Given this list of marker genes Nt5c3, Ada, Dpyd, Cda, Dpys, Pnp, Upp1, Nt5m, Upb1, Urad (NCBI Gene Id 631440), Xdh, Gda, Nt5c, Nt5c1a, Uox, Dnph1, Nt5c2 (5'-nucleotidase, cytosolic II), Upp2, Tymp, Urah, here is a description of the gene set: The chemical reactions and pathways resulting in the breakdown of a deoxyribonucleoside monophosphate, a compound consisting of a nucleobase linked to a deoxyribose sugar esterified with phosphate on the sugar. species: Mus musculus Mouse Gene Set: GOBP_DEOXYRIBONUCLEOSIDE_MONOPHOSPHATE_CATABOLIC_PROCESS